Given this list of marker genes SERPINB2, EIF3E, TACR1, GABRB2, RAD21, TUBB, RFPL3S, THOC2, ADD3, SUMO2, LEPR, TXN, DMXL2, METAP1, UBB, CAPN7, ADAMDEC1, TRIP13, LDHA, TUBA3D, RHOC, ARAP2, PPP2R5A, FAM153A, RIPK1, SRRD, PPBPP2, PRPSAP1, TSPAN6, BAZ1B, NPC1, NASP, TBX19, CHIT1, UQCRC2, SRRM2, SULT1C2, CTDSPL, RWDD2A, CD59, MSC (NCBI Gene Id 9242), PDE2A, ACTR2, ARL4A, PARN, CRY2, ENC1, SP3, EIF3A, DNAJC8, MISP, MPHOSPH8, GLRX, DDB1, EAPP, SLC5A12, VPS26A, SH3BP5, MAGI2, WBP4, PSMA3, SEMA3C, MFN1, CRABP2, GTF2B, NTRK2, UNC93A, SERPINE1, MSMB, PPP1R11, PLOD1, TXNL1, GPATCH8, TNFSF12, ATP6V0E1, SEC61G, RUSC1 (RUN and SH3 domain containing 1), CPM, NCOA1, TSC22D2 (TSC22 domain family member 2), ATP5MF, ASB1, PDXDC1, IGFBP5, G0S2, CUL2, PTGER2, RABL3, CHUK, ATP5PB, DRG1, CXCL3, MTMR6, SERPINE2, STAT3, MDFIC, PFKFB1, MT1E, MKI67, ERGIC3, SLC39A6, TP53BP2, PPP2R2A, KIFC3, COL16A1, PIK3C3, NARS1, FOSL2, RUNX3, DLC1, TRAF1 (NCBI Gene Id 7185), ZNF410, LILRB4, C3AR1, CLPTM1, KCNA3, CSNK2B, TDG, LPP, PTPN9, MCFD2, SYN3, ADAM8, MBOAT7, HUWE1, ZFC3H1, PRPF3, TOP2A, CNTN2, ZNF132, ALDH1B1, OAT, TAF6, SEC11A, SLC11A1, SH3YL1, TMBIM6, TRIM38, CDH5, TFEC, PGRMC1, CALCOCO2, IGSF6 (NCBI Gene Id 10261), ORC4, BRINP1, PECAM1, COL7A1, NUP153 (nucleoporin 153), PPID (peptidylprolyl isomerase D), BANF1, MUC3A, TPP1, ELL2, DICER1, CD63, CDH15, CCL2, PFN1, CPZ, CACTIN, PSMA5, E2F1, CD164, KIFAP3, USP12, PLAGL1, GPX3, MLH1, SLC30A1, BAAT, PLEKHM1, IDH3A, KLHL9, CIR1, PDLIM5, SULT4A1, SERINC5, ANKRD46, ARPC3, PPP1R10 (NCBI Gene Id 5514), GM2A, DNAJC13, MYL6, SSB, NCBP2, MSMO1, ZNF124, EHD1, SDF2, IK, CD53, MYL12A, UBE2L6, NGDN, CEP162, MAPK6, HNRNPA3, LRRFIP1, SUMO1, here is a description of the gene set: from publication Chaussabel D, Semnani RT, McDowell MA, Sacks D, Sher A, Nutman TB (PMID 12663451) Genes up-regulated in comparison of macrophages exposed to L. donovani versus macrophages exposed to 5 worms/well B. malayi. studied in species Homo sapiens Human Gene Set: GSE360_L_DONOVANI_VS_B_MALAYI_LOW_DOSE_MAC_UP Monocyte-derived dendritic cells (DC) and macrophages (MΦ) generated in vitro from the same individual blood donors were exposed to five different pathogens, and gene expression profiles were assessed by microarray analysis. Responses to Mycobacterium tuberculosis and to phylogenetically distinct protozoan (Leishmania major, L. donovani, Toxoplasma gondii) and helminth (Brugia malayi) parasites were examined, each of which produces chronic infections in humans yet vary considerably in the nature of the immune responses they trigger.